The following is a description of a gene set: Esophageal stenosis An abnormal narrowing of the lumen of the esophagus. studied in species Homo sapiens Human Gene Set: HP_ESOPHAGEAL_STENOSIS, and this is the list of marker genes: SAMD9, HLA-B, CTC1, WRAP53, MYH11, RTEL1, COL4A6, NHP2, ITGA6, TERC, DCLRE1B, GRHL2, COL4A5, MALT1, ACD, DKC1, TINF2, STAT3, IKZF1, LAMC2, PARN, USB1, TERT, NOP10, LAMA3, FERMT1, LAMB3, PGM3, GMPPA, NPM1, COL7A1, TYMS